Given this list of marker genes TNNT1, TNNI3, TNNI2, TNNC1, PVALEF, TNNT2, TNNI1, TNNC2, TNNT3 (troponin T3, fast skeletal type), here is a description of the gene set: studied in species Homo sapiens Human Gene Set: GOCC_TROPONIN_COMPLEX A complex of accessory proteins (typically troponin T, troponin I and troponin C) found associated with actin in muscle thin filaments; involved in calcium regulation of muscle contraction.